Given this list of marker genes ARAF, NRAS (NCBI Gene Id 4893), KRAS, MAP2K1, MAP2K2, ALK, HRAS, BRAF, CCND1, RAF1, MAPK3, MAPK1, here is a description of the gene set: EML4-ALK fusion kinase to RAS-ERK signaling pathway. Pathway ID: N00007. Pathway type: Variant. Pathway class: nt06266 Non-small cell lung cancer. studied in species Homo sapiens Pathway Definition from KEGG: EML4-ALK -> RAS -> RAF -> MEK -> ERK -> CCND1 Human Gene Set: KEGG_MEDICUS_VARIANT_EML4_ALK_FUSION_KINASE_TO_RAS_ERK_SIGNALING_PATHWAY